The following is a description of a gene set: studied in species Mus musculus Any process that modulates the frequency or rate of myeloid dendritic cell activation. Mouse Gene Set: GOBP_REGULATION_OF_MYELOID_DENDRITIC_CELL_ACTIVATION, and this is the list of marker genes: Il10, Tspan32, Havcr2, Flt3l, Klrk1, Clec4d, Cd37